Given this list of marker genes SLC41A3, TBPL1, EFS, HAND1, MAPKAPK5, GDAP2, LEP, L1CAM, NLRX1, ACTRT1, TRPV4, ABCB9, TMEM9B, WAS, IGF2R, UAP1 (NCBI Gene Id 6675), PRKAR1A, UBE2Z, SLC37A1, SQOR, XAB2, ZBTB11-AS1, PDGFRA, ULK2, PARP12, ENPP1, KAT6A, GTF3C2, CRAMP1, LCK, ACOX1, ZNF274, GLUL, CAMKK1, ATG16L1, UBL5, RSPO2, TDP2, DNAJB5, EXOC1, CXCL6, CNR2, SEC11A, INPP5A, TRIM25, JUN, RNF114, CERT1, RREB1, FOXI1, YIPF3, SNX4, HDAC11, KIAA1143, RPL5, SELPLG, SMAP2, OTOS, FGF22, IGFLR1, ZXDC, DCAF15, NCK2, RCBTB1, JCHAIN, PREB, MS4A1, SFXN3, SLC41A1, ABHD8, MALAT1, SERP1, RCOR1, SHC1, SSBP4, KLF4 (NCBI Gene Id 9314), N4BP2L1, IDNK, CDT1, SCAND1, RAC2, CHIC2 (cysteine rich hydrophobic domain 2), ARHGAP5, KLHL22, ZNF264, RIPK4, SPRYD3, PCSK2, STAT5B, EPB41, BTG4, SLC25A29, SAA2, MORF4L2, LAPTM4B, PRKAB1, CACUL1, NDUFB11, ERRFI1, CD3E, BIN3, MCM9, HMBOX1, SIT1, CCDC28A, RPS21, SPPL3, CARD19, ICAM2, OSBPL2, BCKDHB, CSDE1, IRF6, SMPD5, TRAPPC12, ST6GALNAC3, ACVRL1, MARCO (macrophage receptor with collagenous structure), SGIP1, QRICH1, SHC3, TPP1, SLC23A3, FASLG, LLGL1, SYNE4, USP47, IER2, RPS19, HDAC9, SLC6A12, MSANTD2, HERPUD1, CCDC191, RMND1, SIAH2, ATP11C, RB1CC1, RHOB, NDUFA6, WDR13, GATAD2B, SLC25A30, LRRC4, DUSP16, STX1A, S100A6, PHIP, FBXO25, EHHADH, TPST2, NUB1, AP2A2, SLC35F6, LGALS4, DGKZ, NINJ1, RIPOR1, PIWIL1, CD72, ACBD3, TNFAIP8L1, KIAA0930, HINFP, TSC22D4, CR2, SF1, PTBP1, CYP2D6, ETS1, MTMR14, PCDH15, WNK1, REXO1, FOXQ1, SEC24D, CRAT, TPCN2, PPP1CC, WBP2 (WW domain binding protein 2), DICER1, E4F1, LONP2, ZFYVE26, RDH5, SPON1, EPAS1, PBX2, RPL13A, IDUA, RPS29, CBFA2T2, CASQ1, CHFR, MAN1A2, ASXL1, PI4KA, TTLL3, MED14, KCNMB4, here is a description of the gene set: from publication Ng SY, Yoshida T, Zhang J, Georgopoulos K (PMID 19345118) Human Gene Set: GSE15330_WT_VS_IKAROS_KO_MEGAKARYOCYTE_ERYTHROID_PROGENITOR_DN Genes down-regulated in megakaryo-erythrocyte progenitors: wildtype versus IKZF1 knockout. Regulation of lineage potential and transcriptional priming by Ikaros. New insight is provided into a bivalent regulation of lineage priming in the HSC and its lympho-myeloid restricted progeny the LMPP by the lymphoid lineage-determining factor Ikaros Whereas Ikaros is responsible for the activation of a cascade of lymphoid expression programs and for the establishment of lymphoid potential from the HSC to the LMPP it is also responsible for the repression of stem cell and erythroid genetic programs that are incompatible with further lineage restrictions emanating from the LMPP species: Homo sapiens